The following is a description of a gene set: The aggregation, arrangement and bonding together of a vacuolar proton-transporting V-type ATPase complex, proton-transporting two-sector ATPase complex that couples ATP hydrolysis to the transport of protons across the vacuolar membrane. Mouse Gene Set: GOBP_VACUOLAR_PROTON_TRANSPORTING_V_TYPE_ATPASE_COMPLEX_ASSEMBLY studied in species Mus musculus, and this is the list of marker genes: Aldob, Tmem199, Tm9sf4, Ccdc115, Atp6v1b1, Vma21